Given this list of marker genes Ubb (NCBI Gene Id 22187), Rps27a, Trim56, Dtx4, Ddx41, Sting1, Nlrp4c, Irf3, Trim32, here is a description of the gene set: electronically inferred by orthology from the curated human pathway Reactome Pathway: Regulation of innate immune responses to cytosolic DNA part of: Cytosolic sensors of pathogen-associated DNA  This event has been computationally inferred from an event that has been demonstrated in another species.<p>The inference is based on the homology mapping from PANTHER. Briefly, reactions for which all involved PhysicalEntities (in input, output and catalyst) have a mapped orthologue/paralogue (for complexes at least 75% of components must have a mapping) are inferred to the other species. species: Mus musculus